Given this list of marker genes SSPN, CREBBP, VHL, EFCAB3, AKT1, PKLR, LDHB, PBRM1, LDHD, TSC2, SETD2, CDH13, ACACA, ALDOB, ACLY, RPTOR, PDGFRB, ARNT, RHEB, CEP290, SLC2A1, BAP1, PTEN, BHLHE41, EP300, RAPGEF5, TOX2, PGM2, PFKM, TGFB3, PSPH, HIF1A, SHMT1, SDS, KSR1, PLOD2, PDGFRA, ALDOC, PFKL, TGFB2, CAMK1, TSC1 (NCBI Gene Id 7248), PGBD5, SDSL, SHMT2, PGK2, AKT1S1, FASN, PKM, VEGFA, ENO2, FLT1, GRB10, MIR21, KDM5C, PGK1, LDHC, PDGFB, DEPTOR, MDH1, TPI1, ENO1, MTOR (NCBI Gene Id 2476), EGFR, HK3, SQSTM1 (NCBI Gene Id 94002), PSAT1, HK2, GPI, STAT3, KDR, HK1, PFKP, ALDOA, PHGDH, GAPDH, KCNJ2, LDHA, ENO3, ME1, TGFB1, PGM1, ENPP3, ZEB1, ACACB, MLST8, here is a description of the gene set: Clear cell renal cell carcinoma pathways species: Homo sapiens Human Gene Set: WP_CLEAR_CELL_RENAL_CELL_CARCINOMA_PATHWAYS